The following is a description of a gene set: Mouse Gene Set: CUI_T_CELL_CD4_CARDIOTROPHIN_1_RESPONSE_DN Cytokines mediate cell-cell communication in the immune system and represent important therapeutic targets. A myriad of studies have highlighted their central role in immune function, yet we lack a global view of the cellular responses of each immune cell type to each cytokine. To address this gap, the authors created the Immune Dictionary, a compendium of single-cell transcriptomic profiles of more than 17 immune cell types in response to each of 86 cytokines (>1,400 cytokine-cell type combinations) in mouse lymph nodes in vivo. A cytokine-centric view of the dictionary revealed that most cytokines induce highly cell-type-specific responses. For example, the inflammatory cytokine interleukin-1β induces distinct gene programmes in almost every cell type. A cell-type-centric view of the dictionary identified more than 66 cytokine-driven cellular polarization states across immune cell types, including previously uncharacterized states such as an interleukin-18-induced polyfunctional natural killer cell state. species: Mus musculus Genes negatively differentially expressed in cell type: CD4+ T cell upon treatment with cytokine: CT-1 in mouse lymph nodes in vivo. from publication Cui A, Huang T, Li S, Ma A, Pérez JL, Sander C, Keskin DB, Wu CJ, Fraenkel E, Hacohen N (PMID 38057668), and this is the list of marker genes: Fos, Junb, Dnajb1, Ppp1r15a, Klf2, Hspa1b, Jun, Hspa1a, Klf6, Btg2